Given this list of marker genes CCNE1, CDKN1B, CCND1, CDK4, PTK6, CDK2, here is a description of the gene set: part of: Signaling by PTK6 PTK6 promotes cell cycle progression by phosphorylating and inactivating CDK inhibitor CDKN1B (p27). PTK6 also negatively modulates CDKN1B expression via regulation of the activity of the FOXO3 (FOXO3A) transcription factor. studied in species Homo sapiens Reactome Pathway: PTK6 Regulates Cell Cycle